Given this list of marker genes PIK3CD (NCBI Gene Id 5293), RPS6KB1, AKT1, PDGFB, PDGFA, MTOR, PDGFRA, AKT3, AKT2, PDGFRB (platelet derived growth factor receptor beta), RPS6KB2, PIK3CA, PIK3CB, here is a description of the gene set: Pathway Definition from KEGG: PDGF -> PDGFR -> PI3K -> PIP3 -> AKT -> MTOR -> S6K Human Gene Set: KEGG_MEDICUS_REFERENCE_PDGF_PDGFR_PI3K_SIGNALING_PATHWAY PDGF-PDGFR-PI3K signaling pathway. Pathway ID: N00039. Pathway type: Reference. Pathway class: nt06273 Glioma. species: Homo sapiens